Given this list of marker genes Atp6v1b1, Atp6v1e1, Atp6v1g1, Atp6v1c1, Atp6v1d, Atp6v1h, Atp6v1g2, Atp6v1a, Atp6v1g3, Atp6v1f, Atp6v1c2, Atp6v1b2, Atp6v1e2, here is a description of the gene set: A protein complex that forms part of a proton-transporting two-sector ATPase complex and catalyzes ATP hydrolysis or synthesis. The catalytic domain (F1, V1, or A1) comprises a hexameric catalytic core and a central stalk, and is peripherally associated with the membrane when the two-sector ATPase is assembled. Mouse Gene Set: GOCC_PROTON_TRANSPORTING_TWO_SECTOR_ATPASE_COMPLEX_CATALYTIC_DOMAIN studied in species Mus musculus